The following is a description of a gene set: from publication Schenk M, Krutzik SR, Sieling PA, Lee DJ, Teles RM, Ochoa MT, Komisopoulou E, Sarno EN, Rea TH, Graeber TG, Kim S, Cheng G, Modlin RL (PMID 22447076) species: Homo sapiens Genes down-regulated in monocytes (24h): muramyl dipeptide versus muramyl dipeptide and M. tuberculosis 19 kDa lipopeptide. human blood monocytes were isolated, activated and harvested at several timepoints In this study, we identified genes that were differentially expressed in human monocytes activated with eiter NOD2L and/or TLR2/1L. Human Gene Set: GSE34156_NOD2_LIGAND_VS_NOD2_AND_TLR1_TLR2_LIGAND_24H_TREATED_MONOCYTE_DN, and this is the list of marker genes: APOL6, NBEA, NBDY, ZNF789, RAB30, RPLP2, RACK1, MCUB, POLG2, MYH3, NAXD, MAN2A1, SEC31B, ADD3, ZNF706, PCSK5, FBXO11, ZNF100, FDX2, PLXDC1, SRSF1, TIMM10, SEC24B-AS1, PIGL, CLYBL, LINC00938, TAB3, FAM136A, SMIM7, FKTN, ZBTB40, NDUFB6, NECAP1, RPL13A, DSC1, FRYL, REG4, ZBED5, LEF1-AS1, KBTBD6, NOP10, JRKL, S100A13, PDPR (pyruvate dehydrogenase phosphatase regulatory subunit), CA6, COX7C, FYB1, RPS25, MIX23, MDM1, RBM34, TAF9, KLRC4, NUP133, EIF2S1, MICU2, GRTP1, LMTK2, CNPY3, MORC2-AS1, UBA52, RPS29, MSH6, ZNF805, AGBL3, MAGEH1, ASNSD1, ATP11C, RPS11, PRDX3, SOX7, MAP1B, ETFRF1, NAA25, ACTN1, MIR99AHG (NCBI Gene Id 54079), C2CD5, SETD1B, RAB11A, DNHD1, SFSWAP, PRKCA, NDUFB4, KLHL3, FAM111A, SMIM27, WHAMM, DCTN3, TIGD1, SPG7, LCDR, CDS2, NR2C1, USP6NL, RABL3, EIF3H, RCN1, ARMCX1, NR2C2 (nuclear receptor subfamily 2 group C member 2), ZNF655 (zinc finger protein 655), PVT1, MAPKAPK5-AS1, VNN2, GXYLT1, PPWD1, METTL25, TMEM243, FAM86C1P, VPS33B, RPL31, ELP2, BAZ1A, SETMAR, FASTKD1, SNHG29, C6orf62, MMD, SARNP, TUBE1 (NCBI Gene Id 51175), BTLA, PAN2, LINC00339, ING2, ZNF667-AS1, UXS1 (UDP-glucuronate decarboxylase 1), COX4I1, TTN, ARPP21, RPL28, HUWE1, BTF3L4, UBE2Z, DIP2B, RAD51C, MNS1, TRMT13, STRIP1, ZNF891, COX16, CEP85L (NCBI Gene Id 387119), TTC3, DDIAS, RPL27, VPS11, ZNHIT6, ABCC1, TENT4A, RBM20, RPL39, EAPP, NSFL1C, PIGP, DDX39B, MTHFD1, ERCC6L2, PPP6R3, HMOX2 (NCBI Gene Id 3163), RBX1, MBIP, MTMR1, DZIP3, METTL16, IL6ST, MTERF3, FBH1, MEST, SECISBP2, NELL2, CDR1, MSL3, PDCD4-AS1, LINS1, RASSF6, MAN1C1, NMT1, MLXIP, PHYH, MTURN, CD8B, MBD5 (NCBI Gene Id 55777), SEPTIN7P2, IFT70B, TRABD2A, PGAP1 (NCBI Gene Id 80055), POLR1D, MAL, RPL35A, RPSA (ribosomal protein SA), HELQ, CLK4, IMPACT, ATP5MJ, SDR39U1, ANAPC4, CCDC136, NDUFAF6